The following is a description of a gene set: Human Gene Set: REACTOME_NUCLEAR_EVENTS_MEDIATED_BY_NFE2L2 species: Homo sapiens Nuclear events mediated by NFE2L2, and this is the list of marker genes: PSMB1, ABCC3, PSMA1, EP300, PRDX1, GSK3B, BTRC, UBC, AREG, ATF4, PSMB3, GSTA1, ME1, TALDO1, MYC, SQSTM1, CCL2, PSMB5, GSR, PSMD2, RPS27A, MAFK, NQO1, PSMC1, PSMA5, TKT, EGF, UBA52, HMOX1, PRKAA2, PSMA6, TXNRD1 (thioredoxin reductase 1), PSMD8, PSMC6, RELA, NFE2L2, PSMD12, PGD, PSMC4, KEAP1, NOTCH1, BACH1, MAFG, CUL1, PSMD6, BCL2L1, PSMD7, CDKN2A, PSMD11, PSMD14, PSMC3, G6PD, PSMA2, PSMB6, GCLM, PSMA4, PSMD3, SKP1, ABCG2, TXN, PSMB4, ABCC1, PSMA3, PSMD1, SLC7A11, SEM1, PSMC5, RBX1, PDGFA, CREBBP, UBB, NFKB1, SRXN1, GCLC, GSTA3, ADRM1, PSMB2, PSMB7, PSMC2, SP1, IDH1, PSMA7, SOD3, BCL2, PSMD13, ABCF2